The following is a description of a gene set: studied in species Mus musculus This event has been computationally inferred from an event that has been demonstrated in another species.<p>The inference is based on the homology mapping from PANTHER. Briefly, reactions for which all involved PhysicalEntities (in input, output and catalyst) have a mapped orthologue/paralogue (for complexes at least 75% of components must have a mapping) are inferred to the other species. Reactome Pathway: Pre-NOTCH Transcription and Translation part of: Pre-NOTCH Expression and Processing electronically inferred by orthology from the curated human pathway, and this is the list of marker genes: Elf3